Given this list of marker genes TBX18, TBX3, ISL1, SHOX2, BVES, MESP1, here is a description of the gene set: species: Homo sapiens The process in which a relatively unspecialized cell acquires specialized features of a sinoatrial (SA) node cell. SA node cells are pacemaker cells that are found in the sinoatrial node. Human Gene Set: GOBP_SINOATRIAL_NODE_CELL_DIFFERENTIATION